The following is a description of a gene set: A negative regulation of smooth muscle contraction resulting in relaxation of vascular smooth muscle. The relaxation is mediated by a decrease in the phosphorylation state of myosin light chain. This can be achieved by removal of calcium from the cytoplasm to the sarcoplasmic reticulum lumen through the action of Ca2+ ATPases leading to a decrease myosin light chain kinase activity, and through calcium-independent pathways leading to a increase in myosin light chain phosphatase activity. Mouse Gene Set: GOBP_RELAXATION_OF_VASCULAR_ASSOCIATED_SMOOTH_MUSCLE species: Mus musculus, and this is the list of marker genes: Irag1, Sod1, Kcnma1, Prkg1, Gucy1a1, Rgs2, Adora2b